The following is a description of a gene set: Human Gene Set: ZNF214_TARGET_GENES from publication Yevshin I, Sharipov R, Kolmykov S, Kondrakhin Y, Kolpakov F (PMID 30445619) Genes containing one or more binding sites for (ZNF214) in their promoter regions (TSS -1000,+100 bp) as identified by GTRD version 20.06 ChIP-seq harmonization. species: Homo sapiens, and this is the list of marker genes: GALM, MYO1B, RASL11A, EGFLAM-AS1, LINC00511, HNRNPU, ELOVL3, TTC39C, BTN3A1, EPB41L5, LIF, MTCO3P12, MTND5P11 (NCBI Gene Id 100506169), PDCD6IP, TTC39C-AS1, ESRRA, MT-TE, MT-ND6, MT-TT, YES1, LINC02086